Given this list of marker genes IFI35, CLNK, FOXF1, IL33, GAB2, LGALS9, F2RL1, IL4R, VAMP3, RASGRP1, SNAP23, SNX4, SPHK2, SPI1, ANXA3, STXBP2, VAMP2 (NCBI Gene Id 6844), UNC13D, GATA1 (GATA binding protein 1), RABGEF1, HAVCR2, CBL, PRAM1 (NCBI Gene Id 84106), IL13RA2, PIK3CD, VAMP7, TYROBP, PLCG2, FGR, IGHE, FCER1A, SLC18A2, STXBP3, S100A13, PRKCE, BCR, ENPP3, NR4A3, GRN (granulin precursor), CX3CR1, TNF, SBNO2, BTK, KIT (KIT proto-oncogene, receptor tyrosine kinase), STXBP1, PTPN6, ADORA2B, SCN11A, HMGB1, IL13, PTGDR, PYCARD, PDPK1, NMI, MRGPRX2, DNASE1, RAC2, GRP, FCER1G, GPR15LG (NCBI Gene Id 387695), TREM2, CCR2 (NCBI Gene Id 90262), IFNG, GATA2, CD84, CD300A, CPLX2 (complexin 2), DNASE1L3, KARS1, LBP (NCBI Gene Id 3929), SNX6, SUCNR1, PIK3CG, ITGAM, STX4, SCNN1B, LYN, LILRA2, MYD88, CHGA, MILR1, PTGDS, FES, SLAMF1, SYK, FERRY3, PLA2G3, DYSF, GKN2, CD177, LAT2, TREX1, CCL3, DOCK2, ADGRE2, FER, TICAM1, ITGB2, LAT, VAMP8, RAB44, here is a description of the gene set: A change in the morphology or behavior of a myeloid cell resulting from exposure to an activating factor such as a cellular or soluble ligand, leading to the initiation or perpetuation of an immune response. studied in species Homo sapiens Human Gene Set: GOBP_MYELOID_CELL_ACTIVATION_INVOLVED_IN_IMMUNE_RESPONSE